Given this list of marker genes CEP19, MBTD1, PECAM1 (NCBI Gene Id 5175), SRBD1, PRKD1, H3C10, HSDL2, UNC13C, CBX5, KCNMB4, PTK2B (NCBI Gene Id 5748), BRD8, CTTNBP2NL, CCNB2, SNAI2, PDE3B, MORN4, FHL2, FRY, HMG20A, C14orf132, ZNF362, TMEM19, CDKN2C, C12orf76, PHTF1, AFF1, SORL1, VPS35L, JAKMIP2, LINC00847, METTL21A, TIA1, KIF15, SLC24A3, GPR155, H2BC5, DCP1B, COMMD3, SIRT5, PALS1, KDM5B, H2BC8, GLCCI1, SIAH1, ZNF512, MEIG1, TOLLIP-DT, SORT1, ANO3, MARVELD2, HCP5, TOP2B, LIPA, NRP1, ABCG1 (ATP binding cassette subfamily G member 1), SPA17, CACNA2D4, MEGF6, CUTALP, ADD3, DNTTIP1, MAT2B, CBLB (Cbl proto-oncogene B), STAT2, HTRA4, NCF2, MAP2K6, SPATA7, LINC02035, PHEX, CFAP20DC, ACADSB, AHI1-DT, KIF3C, MTSS1, GSTA4 (NCBI Gene Id 2941), EHMT1, VPS53, SH3PXD2A, HSD17B11, APBA2 (amyloid beta precursor protein binding family A member 2), PBX1, DBP (D-box binding PAR bZIP transcription factor), SPTBN1, DET1, STAM, ZNF226, RTP4, BUB1, TNS3, LIPT2-AS1, NIPSNAP2, PRUNE2, CLEC2B, ERMP1, RFX5, HMGCL, ZC3H4, SCAF8, MAST4, DTX4 (deltex E3 ubiquitin ligase 4), NOA1, USP3, BTN3A2, MBD5, CARMIL1, TGIF1, PHYH, KIZ, CBR4, DNASE2, SURF1, TRIM22, ADNP, ASB8, SLC35E2B, PTEN, HMMR, CHN1, ZFP62 (ZFP62 zinc finger protein), BCKDHB, UHMK1, ENSG00000284691, ZCRB1, CAT, CCDC14, SERTAD4-AS1, RBPJ, TOB1, RCOR3, EBF2, PCYOX1, SYNRG, KLHDC2, WDR19, LIX1L, DCTN4, CSF1, HNRNPA1 (NCBI Gene Id 780920), STAT1, CCNG2, MGME1, BRD3, PLCB1, PCBP2, LETMD1, SLC24A1, CDC14B, HOXB3, NIN, GRK3, FUCA1 (NCBI Gene Id 2517), ZMYND8, ADGRA3, LNX2, ZFYVE1, CCNG1, GALC, PROM1, GLRX, PLGRKT, ASF1A, SERINC1, CDC25C, PROK2, TBC1D2B, RHOU, CTDSP2, GABRG2, FAM117B, EFHC1, DYNC1I2, TCAIM, TNFRSF11A, C3orf70, C6orf141, ZNF738, SGCE, CDKN1C, ERCC5, AKR1C3 (aldo-keto reductase family 1 member C3), APOLD1 (apolipoprotein L domain containing 1), NAP1L2, MAML2, SMARCA2, ZNF671, PIK3R3, PDZD2, WSCD2, GFPT2, CEP68, CLCN3, LGSN, MDH1B, IRF2, KCNN3 (potassium calcium-activated channel subfamily N member 3), here is a description of the gene set: Genes up-regulated in at day 0 B cell wildtype versus CD40L and IL-2 IL-4 IL-5 stimulated at day 1 B cell wildtype. Human Gene Set: GSE46606_UNSTIM_VS_CD40L_IL2_IL5_DAY1_STIMULATED_BCELL_UP from publication Ochiai K, Maienschein-Cline M, Simonetti G, Chen J, Rosenthal R, Brink R, Chong AS, Klein U, Dinner AR, Singh H, Sciammas R (PMID 23684984) Temporal analysis of B cell activation in vitro using CD40L and IL-2/4/5 cytokines in wild type Irf4+/+ B cells or in mutant Irf4-/- B cells harboring a tet-inducible allele of Irf4. IRF4 expression was restored, or not, in the Irf4-/- background by culturing in the presence of low or high concentrations of doxycycline. The results provide insight in the role of IRF4 expression levels in coordinating different programs of B cell differentiation. species: Homo sapiens